Given this list of marker genes Ccl12, Msrb1, Ccl9, Ccl6, Mt1, Tm4sf1, Ddit4, here is a description of the gene set: from publication Cui A, Huang T, Li S, Ma A, Pérez JL, Sander C, Keskin DB, Wu CJ, Fraenkel E, Hacohen N (PMID 38057668) Genes positively differentially expressed in cell type: Macrophage upon treatment with cytokine: OSM in mouse lymph nodes in vivo. Mouse Gene Set: CUI_MACROPHAGE_OSM_RESPONSE_UP species: Mus musculus Cytokines mediate cell-cell communication in the immune system and represent important therapeutic targets. A myriad of studies have highlighted their central role in immune function, yet we lack a global view of the cellular responses of each immune cell type to each cytokine. To address this gap, the authors created the Immune Dictionary, a compendium of single-cell transcriptomic profiles of more than 17 immune cell types in response to each of 86 cytokines (>1,400 cytokine-cell type combinations) in mouse lymph nodes in vivo. A cytokine-centric view of the dictionary revealed that most cytokines induce highly cell-type-specific responses. For example, the inflammatory cytokine interleukin-1β induces distinct gene programmes in almost every cell type. A cell-type-centric view of the dictionary identified more than 66 cytokine-driven cellular polarization states across immune cell types, including previously uncharacterized states such as an interleukin-18-induced polyfunctional natural killer cell state.